Given this list of marker genes BMP7, MIR145, PAX2, HNF1B, PAX8, here is a description of the gene set: Any process that stops, prevents or reduces the frequency, rate or extent of somatic stem cell population maintenance. species: Homo sapiens Human Gene Set: GOBP_NEGATIVE_REGULATION_OF_SOMATIC_STEM_CELL_POPULATION_MAINTENANCE